Given this list of marker genes HEXB, FUS, ACTN2, PNPT1, SYNE1, TMEM43, TTN, LAMB2, TK2, SARS2, CHAT, SELENON, SNAP25, SLC18A3, STAC3, ORAI1, SYNE2, ALG14, POLG, LPIN1, HACD1, CHRNE, VAMP1, MYH7, LAMA2, SPTBN4, SLC25A1, STIM1, COL13A1, CASQ1, TPM2, CHRNA1, TPM3, COLQ, SYT2, CPT2, SPG11, SIGMAR1, ADGRG6, GOLGA2, ACTA1, ANO5, IFIH1, OBSCN, TRAPPC11, ALDOA, HNRNPK, MYL2, VPS13A, AGRN, MYO9A, ITGA7, PLOD1, RYR1, EMD, CNBP, ALS2, MT-CO1, SLC5A7, FHL1, TRIP4 (thyroid hormone receptor interactor 4), MAP3K20, HNRNPA2B1, SPTLC1, MT-CO3, GFPT1, LMNA, here is a description of the gene set: Human Gene Set: HP_MUSCLE_FIBER_ATROPHY Muscle fiber atrophy species: Homo sapiens